Given this list of marker genes ZNF443, TUBB7P, PCSK5, LIN7B, AMPD1, TRAK2, PHLPP2, CDH5, BARD1 (BRCA1 associated RING domain 1), MFN1, SYCP1, AFDN-DT, ZNF200, COA1, MIR622 (NCBI Gene Id 693207), GLT8D2, TSSK1B, LINC00939, MTOR, SRM, AMBN, GNA13, GPX3, TBX3, UGGT1, CCN3, SLC17A1, ACRV1, DIXDC1, SPATA6, MEF2D, CD86, ASPSCR1, TRPV5, PLIN1, MYO1A, CXCL12, TSC22D2, TPSD1, REG1B, BAALC, RHPN1-AS1, DPEP3, SLC8B1, SLC19A3 (solute carrier family 19 member 3), GLP1R, KCNA6, PTGDS, RORA, LGI2, GTPBP2, LOX, GPR17, CYLD, MORC2, ERVMER34-1, PTPN7, MUC13, GMEB1, TTYH1, SCNN1D, SND1-IT1, HIF1A, TRMT9B, RPS2P45, EVA1B, APOBEC2 (NCBI Gene Id 10930), PPIB, IRF2BP1, G0S2, CHD1, HSD17B10, ZBTB43, COL4A3, SYN1, IER3IP1, PSCA, ZBTB18, TRAF6, CST1, LTK, FRMD8, UBXN1, ZNF671, DTWD1 (DTW domain containing 1), RSPH14, SERPINA4, ATG9A, SNAPC1, FSHR, SFRP4, ADH1A, TRAF3, LY6E, GALNT3, HBEGF, SPATA6L, ZFX, CCDC186, DNAJC11, TNP1, PCYT1A, UNC13B, KDELR3, GS1-600G8.3, DPYSL4, ARPC3, DMP1, MBTPS2, ARAF, ROPN1B, EMC9, PPBP, CNN1, PYY, KIAA0087, FOXA2, AMELY, WDR33, ADAMTS5, LPO, NOCT, LINC00474, ROBO4, ZNF385D, IFNW1, LIMK1, MAP3K14, VPREB3, TRAF3IP2, RASSF8, VPS13B, ITCH, COG5, PTDSS2, ORC1, PPEF1, KLK7, GPLD1, CDC42EP1, MYH7B, MKRN3, APOL5, IQSEC1, FUT4, FERMT1, FOSL2 (FOS like 2, AP-1 transcription factor subunit), C7, BNIP3, B3GALNT1, NXN, ETNPPL, IFNA21, CCDC30, PCDHB8, TFPT, GPR182, FBXO46, WNT5B, KCNE4, RNF138, CUL9, GNA14, MYO1B, PPP1R17, ERCC4, COX5B, KRT85, PALS2, CRISP1, TMEM158, ELF3, CWF19L1, CA9, ZNF267, LIPE, TEAD3 (TEA domain transcription factor 3), LRIG1, ZER1, TPPP3, ERI3, HPR, LMF1, MCF2L, GCK, PAIP2B, PATJ, H4C4, INSL6, ZNF334, SH2B3, PBX3-DT, NFIB, SLC44A1 (solute carrier family 44 member 1), CAMK1D, RNF128, ACKR2, here is a description of the gene set: from publication Nakaya HI, Wrammert J, Lee EK, Racioppi L, Marie-Kunze S, Haining WN, Means AR, Kasturi SP, Khan N, Li GM, McCausland M, Kanchan V, Kokko KE, Li S, Elbein R, Mehta AK, Aderem A, Subbarao K, Ahmed R, Pulendran B (PMID 21743478) species: Homo sapiens Human Gene Set: GSE29618_PRE_VS_DAY7_FLU_VACCINE_MONOCYTE_UP Genes up-regulated in comparison of monocytes from influenza vaccinee pre-vaccination versus those at day 7 post-vaccination. Systems vaccinology has emerged as an interdisciplinary field that combines systems wide measurements and network and predictive modeling applied to vaccinology. Here we used the systems vaccinology approach to study the molecular mechanisms underlying th